The following is a description of a gene set: Mouse Gene Set: GOBP_HEMOPOIESIS species: Mus musculus The process whose specific outcome is the progression of the myeloid and lymphoid derived organ/tissue systems of the blood and other parts of the body over time, from formation to the mature structure. The site of hemopoiesis is variable during development, but occurs primarily in bone marrow or kidney in many adult vertebrates., and this is the list of marker genes: Ccl21b, Clec12a, Tlr4, Aire, Tmem91, Tifab (TRAF-interacting protein with forkhead-associated domain, family member B), Arid3c, Gmpr2, Pbx1, Ror2, Spta1, Pcid2, Ppp3cb, Hif1a (hypoxia inducible factor 1, alpha subunit), Lep, Slc46a2, Tfe3, Cyp2c66, Nhej1, Mmp21, Mafb, Ripk1, Tnfrsf11a, Asxl1, Ppargc1b, Mysm1 (myb-like, SWIRM and MPN domains 1), Brpf3, Lyn (NCBI Gene Id 99963), Ypel4, Meis3, Cd79b, Tpm4, Srp54a, Pck1, Sart1, Mllt3, Cd83, Wnt4, Fzd7, Ercc2, Racgap1, Tnfrsf11b (tumor necrosis factor receptor superfamily, member 11b (osteoprotegerin)), Evi2b, Crtam, Tiparp, Ncor1, Vps33b, Lag3, Fanca, Smarcd3, Sirpa, Tent2, Cbfa2t3, Tesc, Crip2, Kdelr1, Axl, Stk11, Oscar, Kirrel3, Cdk6, Fst (NCBI Gene Id 99160), Leo1, Meox1, Dnaja3, Atf4, Hectd1 (HECT domain E3 ubiquitin protein ligase 1), Atp5if1, Diaph3, Klf11, Pafah1b1, Chd7, Abca15, Dll4, Zfpm1, Wbp1l, Ifng, Ift80, Ciapin1, Mir542, Ltf, Meis1, Prelid1, Il25, Ubash3b, Zc3h12a, Ogt, Cd8a, Efna2, Il1a, H2-DMa (histocompatibility 2, class II, locus DMa), Mir301, Pax1, Mir451a, Tespa1, Sox12, Ccr2, Ifi213, Nr3c1 (nuclear receptor subfamily 3, group C, member 1), Rhoh, Psen1, Cd3d, Ptprj, Thpo, Mettl3, Lrrc8a, Eif2ak2, Large1, Inhba, Ezh2, Trp53, Smarcd2, Zbtb24, Clec1b, Hbb-bs, Fshb, Enpp1, Dhtkd1, Mink1, Mndal, Tnfsf18, Chuk, Sp7, Smarca2, Slc48a1, App (NCBI Gene Id 319425), Kcnk18, Fech, Itm2a (NCBI Gene Id 16431), Cdk13, Ctnnb1, Pparg (NCBI Gene Id 19016), Ighg1, Cxcl15, Ppp3ca, Dcaf1, Mir326, Txnrd2, Nemp1, Mapk14, Rag2, Lef1, Gnas, Zfp36l1, Stat3, Foxp1, Notch2, Lilrb4b, Nfam1, Myc, Igsf23, Ighm, Itfg2, Pou4f1, Cdin1, Ripk2, Gm15915, Sp3, Tirap, Wasf2 (NCBI Gene Id 52063), Tcirg1, Slc1a5, Clec4g, Nkx2-3, Hdac7, Ddias, Mirlet7e, Hax1, Esrra, Cdkn2b, Prrc2c, Smarcb1, Cdh17, Zeb1, Rtkn2, Rps14, Lrrc17, Krt75 (NCBI Gene Id 76250), Vpreb1a, Mir130a, Irf8, Hsp90aa1, Mfsd8, Ifi203, Bmp4, Ndp, Jam3, Pbxip1, Gpr18, Calcr, Tcta, Il4i1, Dhx36, Sipa1l3, Fancd2, Src, Plcb1 (phospholipase C, beta 1), Meis2, Gfi1b, Klhl25, Qki (NCBI Gene Id 66145), Cd3g, Ubd, Jak3, Mir193b, Rasgrp1, Pip4k2a, Traj18, Wdr7, Epsti1, Pik3r6, Klf13, Blvrb, Vegfa, Fli1, Mertk, Cd300lf, Wdr38, Tyro3, Fam210b, Muc19 (NCBI Gene Id 667734), H2-Aa, Dnai4 (NCBI Gene Id 242584), Gabpa, Slc4a1, Hlx, Serpinb9f, Fubp1, Lif, Prex1, Tnfsf11, Vmn1r214, Atp11c, Slc25a38, Ahr, Jagn1, Ccl3, Hhex, Gadd45g (NCBI Gene Id 97898), Fasn, Tcf7, Opa1 (NCBI Gene Id 74143), Ctsl, Exoc6 (exocyst complex component 6), Stat5a (signal transducer and activator of transcription 5A), Farp2, Onecut1, Pla2g3, Casp3, Phf14, Fas, Pias3, Csf3, Mmp14, Ucp2, Mir181c, Ciao3, Add1, Zbtb7b, Tmsb4x, Hnrnpu, Gpr137b, Il11ra1 (NCBI Gene Id 16157), Gpr137, Mir451b (microRNA 451b), Rac1, Msh2, Irf1, Mir126a, Samd9l, Relb, Myd88, Ehbp1l1, Hoxb3, Pdcd2, Prr7, Gm36723, Ptbp3, Hspa9, Wnt3a, Csf1r, Atf2, Cul4a, Klf10, Cldn18, Sin3a, Mpzl2, Syvn1, Dhrs7b, Cd4, Rps6, Pirb, Rhag, Zfp36 (NCBI Gene Id 22695), Apcs, Mlf1, Kitl, Lig4 (NCBI Gene Id 319583), Rsad2, Dpf2, Satb1, Il2ra, Gon4l, Nrarp, Tcf3, Lmbr1l, Ptprc, Il1b, Ptk2b, Ptpn22, Bcl11b, Ctsk (cathepsin K), Gli3, Kcp, Zfp36l2, Mir145a, Dpp4, Wnt2b, Malt1, Rnf41, Prdm1, Stat4, Ncaph2, Trpm2, Sfxn1, Hcls1, Ppp4r2, Pml, Gp9, Mir150, Atg5, Cd34, Epb42, Bak1, Atg7, Cflar, Ccl19, Adrm1, Itgb8 (NCBI Gene Id 320910), Tnfaip3, Stk3, Smarcd1, Tubb1, Clec4d, Nrros (NCBI Gene Id 224109), Yy1, Gata2, Rlig1, Tmem14c, Bloodlinc, Itgb3, Gm11690, Abcb10, Tnfsf4, Tcf15, Csf1, Ptn, Fut7, Ager, Gp1bb, Pbrm1, Sox4, Ninj1, Dicer1, Sart3 (squamous cell carcinoma antigen recognized by T cells 3), Col24a1, Gata3, Ankle1, Terc, Pilrb1, Tfrc (transferrin receptor), Xrcc6, Il10, Ptprq, Isg15, Fzd8, Lgals8, Creb1, Ptpn11, Rbp1, Mdk, Casp8, Xrcc5, Srf, Cd44, Rara, Ptprz1, Mtor, Erfe, Anln, Pus7, Il17a, Herc6, Mfap2, Siglecg, Foxo3, Uba5, Ythdf2, Ston2, Actl6b, Braf (Braf transforming gene), Il7r, Ptcra, Kat6b, Adam17, Clpb, Tob2, Cd27, Prdm16, Ccr1, Atm, Fes, Tnfrsf13b, Ctla4, Sptb, Cyp26b1, Vps54, Tyrobp, Ufl1, Fgl2, Mettl14, Prdx3, Hba-a1, Il12a, Junb, Batf, Ifi208, Cnn2, Cdkn2a, Shh, Ptpn2, Cd19, Slamf9, Mir873a, Fam3c, Cd40lg, Alas1, Babam1, Spi1, Bmyc, Pir, Pla2g10, Lgals9, Ebp, Cd81, Ccr6, Slc37a4 (NCBI Gene Id 14385), Zbtb7a, Epo, Tusc2, Cd28, Cd24a, Rabgap1l, Gba1, Ccl5, Twsg1, Sox13, Tmem190, Etv2, Loxl3, Ifnar2 (interferon (alpha and beta) receptor 2), Ocstamp, Il18r1, Ms4a1, Tmem143, Rps19, Zmiz1, Phf10, Fbxw7, Ifi209, Chmp5, Camk4, Fzd5, Il7, Arid2, Fgfr3, Lbr, Cd79a, Egr1, Myh9, H2-Ea, Ifi203-ps, Abi1, Smarca4, Dock10, Nfkbid, Bmi1, Yjefn3, Prkdc (NCBI Gene Id 19090), Zfp683, Pglyrp2, Hmox1, Plscr1, Ctc1, Sp1, Cited2, Dock7, Adgrf5, Gata1, Acin1, Inpp4b, Zc3h8, Smarcc2, Spib, Flt1, Pygo1, Fbn1, Glrx5, Fos, Rrs1, Psen2, Notch1, Duxbl1, Hoxb7, Zswim9, Ssbp3, Il15, Rras, Epha2, Kat5 (K(lysine) acetyltransferase 5), Zap70, Brd7, Gab2, Kcnq1, Mixl1, G6pd2, Eomes (NCBI Gene Id 97512), Zfp385a, Ang, Rora, Srp54b, Lilrb4a, Ccr9, Ccr7, Actb, Heatr9, Nfe2l2, Faxdc2, Cr2, Kit, Gpr55, Wnt1, Tspan2, Sh3rf1, Mknk2, Pla2g2d, Zfp609, G6pdx, Nfe2l1, Mir144, Bcl11a, Gas6, Tshr, Prkx, Trib1, Flt3 (FMS-like tyrosine kinase 3), Hspb1, Lfng (NCBI Gene Id 16848), Mir125a (microRNA 125a), Hes1, Zfp980, N4bp2l2, Tbk1, Nkap, Ahsp, Ddrgk1, Irgm1, Myo1e, Rogdi, Irf2bp2, Gp5, Nf1, Flcn, Bves, Stap1, Rag1, Tgfb2, Lipa, Melk, Kdr, Tnrc6c, Mir223, Ext1, Aqp8, Adgrg3, Il2, Il1rl2, Smpd3 (sphingomyelin phosphodiesterase 3, neutral), Tafazzin, Rhoa, 3830403N18Rik, Fnip1, Foxn1, Psmb11, Slc9b2, Vps33a, Dcstamp, Clec5a, Tmem176b, Nlrp3, Gpatch8, Cxcl1, Gimap5, Rb1, Mr1, Zbtb46, Ccn4, Skic8, Hmgb3, Tcim, Kat2a, Batf3, Tacc3, Ceacam1, Ifi207, Tcaf2, Slc4a2, Smarce1, Anxa2, Ndfip1, Wdr1 (WD repeat domain 1), Rc3h1, Runx1 (NCBI Gene Id 12394), Mir143, Tmod3, Actn1, Evi2, Rptor, Plek, Il21, Mfhas1, Ighe, Sox6, Il15ra, Dock11, Tpo, Rassf2, Serpinb12, Wnt10b, B2m, Hdac5, Trim58, Fosl2, Itgb6, Iapp, Srsf4, Rc3h2, Dclre1c, Cebpd, Tgfb1, St3gal1, Cyld, Kat8, Ankrd54, Paf1, Hs1bp3, Batf2, Pira1, Clec2i, Ctnnbip1, Pld4, Pou2f2, Bcl2, Dmtn, Anxa1, Lck, Spn, Laptm5, Kat7, Tsc1, Clec2d, Il18, Alas2, Pde1b, Il5, Myb, Tet2, Hrnr, Prkca, Lyl1, Fgfr2, Mir155, Ccl9, Ap2a2, Rbfox2 (NCBI Gene Id 93686), Themis, Irf4, Syk, Bmp2, Glo1, Gimap1, Otud5, Meaf6, Il6ra, Zfp950, Vmn2r74, Gimap3, Fadd, Klf1, Foxp3 (forkhead box P3), Mir122, Ap3b1, Card11, Snx10, Runx2, Rpa1, Lgals1, Itpkb, Il4ra, Ripk3, Setd1a, Clcf1, Klf2, Il23a, Ihh, Shb, Smad5, Nbeal2, Ets1, Actl6a, Cd69, Jak2, Nme2, Mitf, Eif2ak1, Gpr183 (G protein-coupled receptor 183), Slc25a40, Kctd9, Il20, Agpat5, Rbm47, Gpr171, Med1, Cd101, Heph, Apc, Bax, Il36b, Ada, Ppp2r3c, Blm (NCBI Gene Id 12144), Csf2, Gpatch4, L3mbtl1, Rhd, Cd1d1, Prtn3 (NCBI Gene Id 19152), Abl1, Brd4, Brd2, Bap1, Entpd7, Eml1, Rarg, Vav1, Tpd52, Dlk1, Dtx1, Slc39a7 (solute carrier family 39 (zinc transporter), member 7), Acvr2a, Stat6, Zfp35 (NCBI Gene Id 22694), Flna, Plcl2, Lox, Apobec3, Ly6d, Esco2, Tcea1, L3mbtl3, Rbpj, Vps13a, Il12b, Fcer1g, Il17d, Jmjd6 (NCBI Gene Id 70547), Mef2c (myocyte enhancer factor 2C), Slc25a5, Top2a, Foxj1, Ltbr, Epas1, Pabpc4, Jag1, Wnt5a, Tmem64, Ikzf3, Ep300, 4930474N05Rik, Socs5, Tnfsf8, Vsir, Il27, Prg4, Pim1, Pink1, Dnajb9, Kmt2e, 6030468B19Rik, Ifi214, Skint1, Prmt1, Cd74, Ireb2, Btnl1, Tnfsf9, Nme1, Eeig1, Znhit1, Bad, Dyrk3, Krtap5-5, Slc8a3, Rabl3, Il3, Hba-a2, Mir146, Pgm3, Runx3, Bpgm, Thoc5, Tlr2, Sirt1, Stat1, Hmgb1, Slc7a6os, Ercc1, Eef2, Tal1, Smap1, Mir18, Ctla2a, Armc6, Ank1, Il17c, Prdx2, Trim10, Senp1, Nckap1l, Sbno2 (NCBI Gene Id 216163), Mb, Igkc (immunoglobulin kappa constant), Pira12, Zbtb1, Sod2, Il9r, Rbmy, Txk, Scart2, Chd2, Cdc73 (NCBI Gene Id 96910), Arid4a, Ccr1l1, Mir20a, Bcr, Cartpt, Kmt2a, Nkx2-5, Vmn1r13, Bbln, Socs1, Prxl2a, Nfatc1, Ncapg2, Fbxo7, Adgrf4, Pglyrp3, Mir19a, Rac2, Hyal2, Mir145b, Tnfaip6, Ascl2, Sos2, Ldb1, Etv6, Hoxb4, Tox, Btnl6, Maf, Mir92-1, Il4 (NCBI Gene Id 16189), Pdgfrb, Nfix, Adam8, Ostm1, Flvcr1, Polm, Il6, Ccl20, Snai2, Zfp608, Sema4a, Cd109, Zbtb32, Maea, Psap, Tspo2, Ly9, Foxc1, Muc4, Btk, Bcl2a1d (NCBI Gene Id 12047), Adar, Clptm1, Acp6, Dock1, Slamf8, Glul, Mpl, Gab3, Cebpg, Hdac9, Rbm15, Gps2, Il34 (NCBI Gene Id 76527), Zbtb16, Asxl2, Prkcz, Trex1 (NCBI Gene Id 22040), Pf4, Tnf, Pnp, Zfat, Klf4, Usp44, Lepr, Hdac6, Atp7a, Tnfsf13b, Abl2, Kcnab2, Slamf6, Gpc3 (NCBI Gene Id 14734), Add2, Twist2, Ptger4, Lyar, Eif6, Cdk5rap3, Itgam, Arid1a, Traf3ip2, Nfatc3, Tmem178, Ikzf1, Tsc22d1, Cebpa, Jun, Tmem176a, Thsd1, Cnot4, Nedd9, Tmem131l, Flt3l, Egr3, Adipoq, Dll1, Mpig6b, Fshr, Ifi206, Dnase2a, Il2rg, Cebpb, Hsf1, Pik3r1, Ntrk1, Sfrp1 (secreted frizzled-related protein 1), Mir99a, Hoxa5, Azi2, Picalm, Ttc7, Cacnb4, Hba-x, Xrcc4, Bcl6, Plcg2, Rpl22, Tbx21, Hoxa7, Angpt2, Cbfb, Bcl3, Dock2 (dedicator of cyto-kinesis 2), C1qc, Brd1, Mturn, Nfil3, Lrrk1, Tescl, Cox10, Kat6a, Coa5, Hotairm1, Naglu, Acvr1b, Ctr9, Hoxb8, Sco1, Siglec15, Cd46, Ptpn6, Atxn1l, Ifnz (interferon zeta), Armc5, Scin, Ccdc134, Ambra1, Ncoa6, Id2, Jag2, Tjp2, Selenow, Pglyrp4, Cmtm7, Sbds, Il33, Prl2c3, Tgfbr3, Mir125b-1, F2rl1, Igtp, Pou2af1, Tmem98, P4htm, Patz1, Atp6ap1, Trem2, Srp54c, Tnfrsf9, Thra, Tlr9, Hoxa9, Erbb2, Sh2b3, Clec4e, Stat5b, Angpt1, Fancb, Rorc (NCBI Gene Id 19885), Wwp1, Kdm1a, Fam20c, Lmo2, Igkj5, Nfkbia, Inpp5d, Rest, Fstl3, Ccdc39, Hscb, Trf, Dact2, Btn2a2, Gpr68, Hes5, H2-M3 (NCBI Gene Id 14991), Pknox1, Mir17, Ace, Brca2, Stk4, Itpripl1, Sash3, Smad7, Ing5, Mrgprx1, Rcor1, Cdkn1c, Gsk3b, Sfrp2, Itk, Pdgfra, Hmga1, Ifnb1, Dusp10, Heatr3, Arhgef7, Atf7, Dab2, Tek, Hells, Pithd1, Xbp1, Mfap5, Sos1, Mecom, Top2b, Csf3r, Slamf1, Cib1, H2-Oa, Drosha, Il1rl1, Pou4f2, Sh3pxd2a (SH3 and PX domains 2A), Vnn1, Gpr89, Arih2, Sgpl1, Zfp784, Cracr2a, Tgfbr2, Cd3e, Ahctf1, Il9, Mfng, Clec2g, Carmil2, Fbxo21, Traf6, Hspa1b, Smarcc1, Car2, Il31ra, Fzd9, Ap3d1, Pou1f1, Pglyrp1, Nudt21, Hmgb2, Pdgfb, Nfkbiz, Mir19b-1, Men1, Mir125b-2, Slc11a2, Cebpe, Arl11, Gp1ba, Rab7b